The following is a description of a gene set: Genes containing one or more binding sites for (MTHFD1) in their promoter regions (TSS -1000,+100 bp) as identified by GTRD version 20.06 ChIP-seq harmonization. Human Gene Set: MTHFD1_TARGET_GENES species: Homo sapiens from publication Yevshin I, Sharipov R, Kolmykov S, Kondrakhin Y, Kolpakov F (PMID 30445619), and this is the list of marker genes: KCTD20, PGK1, PCBP1-AS1, EEF1A1, SNRNP35 (NCBI Gene Id 11066), CLASP2, ZCCHC8, FOXK2, PCBP1 (NCBI Gene Id 5093), MTHFD1, LINC03072, BCL9L, HNRNPK, RNF6, KNTC1, RNU6-1, PXT1 (peroxisomal testis enriched protein 1), NAA38, KEAP1, PALLD, RMI1, H4C3